The following is a description of a gene set: Human Gene Set: GAVISH_3CA_METAPROGRAM_EPITHELIAL_EPI_1 from publication Gavish A, Tyler M, Greenwald AC, Hoefflin R, Simkin D, Tschernichovsky R, Galili Darnell N, Somech E, Barbolin C, Antman T, Kovarsky D, Barrett T, Gonzalez Castro LN, Halder D, Chanoch-Myers R, Laffy J, Mints M, Wider A, Tal R, Spitzer A, Hara T, Raitses-Gurevich M, Stossel C, Golan T, Tirosh A, Suvà ML, Puram SV, Tirosh I (PMID 37258682) Genes upregulated in subsets of cells of a given type within various tumors In this study, an extensive analysis was conducted to define meta-programs (MPs) capturing intra-tumor heterogeneity across a spectrum of tumor types. The approach utilized non-negative matrix factorization (NMF) to analyze each cell type separately within individual tumor samples. This involved the analysis of malignant cells, macrophages, fibroblasts, endothelial cells, epithelial cells, T-cells, and B-cells. NMF was executed with varying parameter values (K=4, 5, 6, 7, 8, 9), thereby generating 39 programs for each cell type per sample. Each NMF program was summarized by the top genes based on NMF coefficients.\nRobust MPs were then delineated for each cell type using a set of stringent criteria, including recurrence within the same tumor, similarity to programs in other tumors, and non-redundancy within a tumor. Subsequently, these robust NMF programs were clustered (per cell type) based on Jaccard similarity, leading to the identification of MPs associated with each cell type.\nTo enhance the quality of the MPs, a refinement steps were undertaken, involving the removal of MPs suspected of reflecting low-quality data (with an overrepresentation of ribosomal proteins or mitochondrial-encoded genes), single-study inclusion, or similarity to miss-annotated cell types. species: Homo sapiens, and this is the list of marker genes: CD151, GPRC5A, AHNAK, ADIRF, TIMP3, CD55, UPK3B (NCBI Gene Id 80761), IGFBP7, S100A10, EMP2, FMO2, ANXA2, AGER, RDX, ANOS1, CAV2, VEGFA, CLIC3, CAV1, TNNC1 (NCBI Gene Id 7134), SCEL, RAB11FIP1, GAS6, SPARC, IL32, AQP4 (NCBI Gene Id 50660), SEMA3B, CLDN18, CST6, KRT19, PDLIM2, RTKN2, SUSD2, LIMCH1, ANXA3, C19orf33, GGTLC1, SPOCK2, CLIC5, LMO7, S100A4, RGCC, CYP4B1, TSPAN13, KRT7, ANKRD29 (ankyrin repeat domain 29), CEACAM6, MYL9, SLC39A8, IFI27 (interferon alpha inducible protein 27)